The following is a description of a gene set: Human hepatocellular carcinoma (HCC) heterogeneity promotes recurrence and therapeutic resistance. We recently have demonstrated that inflammation favors hepatocyte retrodifferentiation into progenitor cells. Here, we identified molecular effectors inducing HCC metabolic reprogramming, chemoresistance and invasiveness of retrodifferentiated stem cells. Spheroid cultures of human HepaRG-progenitors (HepaRG-Spheres), HBG-BC2, HepG2 and HuH7 cells and isolation of side population (SP) from HepaRG cells (HepaRG-SP) were followed by transcriptomics, signaling pathway analysis and evaluation of chemotherapies. Gene expression profiles of HepaRG-SP and HepaRG-Spheres were enriched in signatures related to cancer stem cells, metastasis and recurrence and showed that HepaRG-progenitors can further retrodifferentiate into a more immature state. The transcriptome from these stem cells matched that of proliferative bad outcome HCCs in a cohort of 457 patients. These HCC stem cells highly expressed cytokines triggering retrodifferentiation and displayed high migration/invasion potential. Importantly, they showed changes in mitochondrial activity with reduced membrane potential, low ATP production and high lactate production. These changes were in part related to angiopoietin-like 4 (ANGPTL4)-induced upregulation of pyruvate dehydrogenase kinase 4 (PDK4), an inhibitor of mitochondrial pyruvate dehydrogenase. Interestingly, up-regulation of ANGPTL4 and PDK4 paralleled that of stem cells markers in human HCC specimens. Moreover, the PDK4 inhibitor dichloroacetate reversed chemoresistance to sorafenib or cisplatin in HCC stem cells derived from four HCC cell lines. In conclusion, retrodifferentiated cancer cells develop enhanced invasion and therapeutic resistance through ANGPTL4 and PDK4. Restoration of mitochondrial activity in combination with chemotherapy represents an attractive therapeutic approach in HCCs. from publication Fekir K, Dubois-Pot-Schneider H, Désert R, Daniel Y, Glaise D, Rauch C, Morel F, Fromenty B, Musso O, Cabillic F, Corlu A (PMID 30837223) studied in species Homo sapiens Human Gene Set: FEKIR_HEPARG_SIDE_POP_VS_HEPARG_DN Genes down-regulated in the cancer stem HepaRG-SP vs HepaRG at 10 days of differentiation, and this is the list of marker genes: HINT3, KAT14, FADD, ARL4D, FBLL1, PLAC8, DCN, H3C12, GPR88 (NCBI Gene Id 54112), RPS3, TMEM82, PPP1R3B, FRAT1, MMP7, ADH1C, CEBPZOS, NFYB, SLC39A5, RAD51D (NCBI Gene Id 5892), ISL1-DT, TOB2, GGN, ADH1B, LINC01124, ANGPT1, S100A8 (S100 calcium binding protein A8), ITGA10, TSC22D3, FPGT (fucose-1-phosphate guanylyltransferase), WDTC1, DEPP1, SPINT3, NUDT16L2P, CCDC172, RRH, FOXA1, CYP4B1, NT5M, FAM222B, FGF14-AS2, CABP5, RPL13AP17, SOWAHD (NCBI Gene Id 648756), PCOLCE, CA5BP1, PPP1R16A (NCBI Gene Id 84988), HCG18, CXCR3, IGFBP2, OTOF, SMIM3, NNAT, OR11A1, ASB13, VEGFB, FAM13A, SLC23A3 (solute carrier family 23 member 3), PPP1R3C, PYGO2, RNF43, CXCL13, FMO5, PCTP, HSPB3, ENSG00000290964, LY6D, GADD45G, AMY2B, VPS37D, GPM6B, ZBED3-AS1 (ZBED3 antisense RNA 1), PANTR1, IER5L, CIDEC, FOXB1, GLYCTK, MYH14, DACH1, CCM2, RPP25L, DSTNP2, PRDX6-AS1, MAP3K13, MAFB, AZGP1P1, CEACAM20, SAA3P, VSX1, SERPINA2, LINC02714, SLC12A6, OSCAR, NORAD, CEBPB, LINC00847, KCTD21, BTNL8, NUDT8, LYRM9, KRTAP5-2, TLN2, TIGD5, ACADL, PIM3, C1QTNF1-AS1, DDIT4 (NCBI Gene Id 54541)